The following is a description of a gene set: Mouse Gene Set: GOBP_ADHERENS_JUNCTION_ASSEMBLY The aggregation, arrangement and bonding together of a set of components to form an adherens junction. An adherens junction is a cell-cell junction composed of the epithelial cadherin-catenin complex at which the cytoplasmic face of the plasma membrane is attached to actin filaments. species: Mus musculus, and this is the list of marker genes: Zfp703, Actb, Fer, Abi2, Hipk1, Pak2, Tbcd, Ctnnb1, Vcl, Jam3, Dlg5 (NCBI Gene Id 97944), Smad7, Ramp2